Given this list of marker genes CBLB, PELI2, AIRIM, IL23A, OSTM1, BUD23, TTC19, KDM6A, MAPK1IP1L, QPCT, NFX1, PLEKHB2, MBTPS1, ADNP2, TMEM131L, ARIH1, SH2B3, MAP3K2, ZNF746, TDG, CD6, CEBPZ, ZNF200, EIF5B, ATMIN, VCF1, ZXDA, ZNF462, TPRG1L, TMEM70, MRPS23, NUBP1, SLC25A32, CREM, SYNM, SPATA2, ZNF350, RRAGC, SMAD7, EMC8, TNIP2, RNF130, LRPAP1, EP400, S1PR1, DUSP11, HCG18, CDK12, NAT9, WDR73, RRP12, EMG1, SLC7A1, E2F6, PTGER4 (NCBI Gene Id 5734), MCAT, ALG13, BACH2, IL7R, TMEM68, ATG101, NIPBL, NOSIP (nitric oxide synthase interacting protein), NOP2, SACS, KCTD12, NUFIP1, SLC35D1, CSNK1E, NBN, ARHGAP21, RALA, NOTCH1, CCDC93, RALGAPB, HCFC2, DSE, ZSCAN32, HERC6, SLC30A7, TRMT61A, BBIP1, ZFP36 (NCBI Gene Id 7538), IWS1, IER2, CSRNP1, NIPA2, POLR1A (RNA polymerase I subunit A), ABCF1, VMA21, NUP98, KTI12, SMURF1, RASA3, ATG14, MFAP3, GAR1, ITPKB (NCBI Gene Id 3707), CDK5R1, THAP7, MTUS1, PTP4A1, EPB41L4A, PSMA3-AS1, HIF1A, RAPGEF6, CAST, CDC42EP3, RASSF2, SHISAL2A, TEX261, POLR3B, OTUD4, GPR18, REL, NDUFAF4, NOP16, MAST4, HIC2, UBASH3B, SDHAF2, TMEM243 (transmembrane protein 243), SPRY1, FCMR, PRMT6, LZTS3, MED29, TAGAP, CTSO, TAF9B, MIR17HG, SLCO3A1, CENATAC, MYLIP, TMBIM1, DERL1, NXT1, VAV3, WDR43, RPF1, ZBTB9 (NCBI Gene Id 221504), MAPRE2, ICOS, ARFGEF2, GFOD1, TRMT10C, NR4A1, MTOR, NXF1, FYCO1, POGK, FKRP, PUS1, R3HDM4, MTMR6, SIRT1, MAPKAPK2, CHMP7, TRIM39, ZNF263, ANXA1, MRPL20, TRAPPC4, NGDN, SLC25A44, UBL3, GNL3, PDGFA, GPATCH4, KCNK15-AS1, SEC62, LEPROTL1, NR4A3, TOLLIP, MARS2, IFT20, LINS1, MFSD1, TMEM33, PLEK, TSPYL2, GTPBP4, MTHFD2L, ZFAND4, SDCBP2-AS1, CD83, LYSMD2, ARID5B, SLC11A2 (solute carrier family 11 member 2), SLC38A2, ZNF416 (NCBI Gene Id 55659), NGRN, DDX27, ZNF2, NRIP1, C9orf78, GNL2, TRAPPC13, here is a description of the gene set: The aim of this dataset was to study in detail the transcription kinetics initiated by cytokine IL-4 in early differentiation of Th2 cells. studied in species Homo sapiens Genes up-regulated in comparison of CD4 T cells treated with IL4 and anti-IL12 at 2 h versus those at 72 h. Human Gene Set: GSE17974_2.5H_VS_72H_IL4_AND_ANTI_IL12_ACT_CD4_TCELL_UP from publication Elo LL, Järvenpää H, Tuomela S, Raghav S, Ahlfors H, Laurila K, Gupta B, Lund RJ, Tahvanainen J, Hawkins RD, Oresic M, Lähdesmäki H, Rasool O, Rao KV, Aittokallio T, Lahesmaa R (PMID 20620947)